Given this list of marker genes ZNF250, MEIS1, RAB31, MEX3C, SEMA4A, ALYREF, MAOB (NCBI Gene Id 4129), TAFA2, SZRD1, COBLL1, RAB30, PPIF, MUC7, MAGI3, FBXW11, POU2F1, FUT11, EIF2AK4, CTNNB1, SNRPD1, GABRB2, ONECUT2, SLC6A2, RBM43, CHAC2, MACIR, CALCR, SMOX, RDH14, ARMH4 (NCBI Gene Id 145407), ADIPOR2, SERPINB5, CCDC50, NT5C1B-RDH14 (NT5C1B-RDH14 readthrough), PIP4P1, GLCCI1, ERI2, NOL10, ZFYVE26, AK9, PEA15, MED6, RCE1, TRIL, ERBB4, MGAT5B, ARIH1, ROBO1, JPH4, LSAMP, ABCC6, ARL8B, UNG, SP1, NOLC1, UTRN, ARF3, DCAF6, PFN2, CCN1, PGGT1B, CIBAR1, RCSD1, SLC4A1AP, VNN1, MAN1A2, CNGA1, TMEM254, CRLS1, ZYG11B, DLGAP1, NKAPD1, LPGAT1, PELO, SLC16A12, FAM170B, PTPN4, STAM, LIN28B, RACGAP1, EBLN2, RAPGEF2, EIF4ENIF1, UBE2E3, CACNG6, TP63, ZNF135, ARPC5, STARD13, ITGB5 (NCBI Gene Id 3693), DLG3, ARMH3, DACT1, OXSR1, here is a description of the gene set: species: Homo sapiens Human Gene Set: MIR4733_5P Genes predicted to be targets of miRBase v22 microRNA hsa-miR-4733-5p in miRDB v6.0 with MirTarget v4 prediction scores > 80 (high confidence targets). from publication Chen Y, Wang X (PMID 31504780)